The following is a description of a gene set: Human Gene Set: WP_FBXL10_ENHANCEMENT_OF_MAPERK_SIGNALING_IN_DIFFUSE_LARGE_BCELL_LYMPHOMA FBXL10 enhancement of MAP/ERK signaling in diffuse large B-cell lymphoma studied in species Homo sapiens, and this is the list of marker genes: KDM2B, H3C6, H3C15, H3C4, H3C8, EED, PCGF1, H3C12, DUSP6, H3C11, BCOR (BCL6 corepressor), H3C1, H3C14, H2AZ2, H2AB3, H2AJ, RNF2, H2AX, H2AB2, H3C7, SUZ12, H3-3A, H3-3B, MACROH2A2, EZH2, MAPK1, H3C13, MAPK3, BCL6, MACROH2A1, H2AB1, H3C10, H2AZ1